The following is a description of a gene set: Formation of RNA Pol II elongation complex Human Gene Set: REACTOME_FORMATION_OF_RNA_POL_II_ELONGATION_COMPLEX studied in species Homo sapiens, and this is the list of marker genes: POLR2J, GTF2H4, LEO1, POLR2H, SUPT6H, NELFA, POLR2G, MNAT1, CDK7, SKIC8, GTF2H1, SUPT5H, NELFE, ELOA, CCNH, NCBP2, TCEA1 (NCBI Gene Id 7865), NELFCD, ERCC3, CTR9, GTF2H3 (NCBI Gene Id 2967), ELL, CCNK, ERCC2 (NCBI Gene Id 7269), GTF2F1, POLR2C, POLR2D, MLLT1, POLR2A, ELOB, CTDP1, POLR2F, EAF2 (ELL associated factor 2), CDC73, CCNT2, POLR2I, SUPT16H, SSRP1, CCNT1, POLR2B, POLR2L, PAF1, SUPT4H1, GTF2F2 (general transcription factor IIF subunit 2), GTF2H5, POLR2E, POLR2K, AFF4, CDK9, GTF2H2, EAF1, NCBP1, RTF1, NELFB, ELOC, MLLT3, IWS1, ELOA2